Given this list of marker genes Ccl22, Dido1, Egfem1, Rwdd1, Tfpi2, Crisp4, Zzz3, Rubcnl, Rrp36, Lrp2bp, Xpot, Krt33a, Daam1, Bccip, Actmap, Hsf2bp, Lrp5, Fam169a, Ncor1, Mrps2, Ildr1 (immunoglobulin-like domain containing receptor 1), Immp1l, Golt1b, Zfp846, Rab9b, Nxpe4, Pptc7, Ncoa6, Slc25a33, Bloc1s6, Ywhae, Cacnb4, Ap5m1, Smc6 (NCBI Gene Id 67241), Hars2, Slc45a4, F2rl1, Pi4k2b, Cdc73, Fbln2, Cd2ap, Npas3, Ppp4r3b, Cfap298, Etf1, B230219D22Rik, Cbfb, Rprd1a, Rnf38, Bhlhe22, Zfhx4, Ctsc, Clca2, Camkk2, Radx, Selenot, Tm9sf2, Zc3h12c, Fam114a1, Slc40a1, Tmem68, Wdr26, Tmem267, Pi15, Rp9, Inpp4b, Etnk2 (ethanolamine kinase 2), Setd6, Cldnd1 (claudin domain containing 1), Insyn2b, Wdr11, Pds5b, Mdga2, Ccdc71l, Myct1, Akna, Pcsk5, Pals1, Eif4enif1, Ubfd1, here is a description of the gene set: species: Mus musculus Mouse Gene Set: MIR_6970_5P from publication Chen Y, Wang X (PMID 31504780) Genes predicted to be targets of miRBase v22 microRNA mmu_miR_6970_5p in miRDB v6.0 with MirTarget v4 prediction scores > 80 (high confidence targets).